The following is a description of a gene set: Genes up-regulated in CD34+ hematopoetic cells by expression of NUP98-HOXA9 fusion off a retroviral vector at 16 days after transduction. Human Gene Set: TAKEDA_TARGETS_OF_NUP98_HOXA9_FUSION_16D_UP NUP98-HOXA9, the chimeric protein resulting from the t(7;11)(p15;p15) chromosomal translocation, is a prototype of several NUP98 fusions that occur in myelodysplastic syndromes and acute myeloid leukemia. We examined its effect on differentiation, proliferation, and gene expression in primary human CD34+ hematopoietic cells. Colony-forming cell (CFC) assays in semisolid medium combined with morphologic examination and flow cytometric immunophenotyping revealed that NUP98-HOXA9 increased the numbers of erythroid precursors and impaired both myeloid and erythroid differentiation. In continuous liquid culture, cells transduced with NUP98-HOXA9 exhibited a biphasic growth curve with initial growth inhibition followed by enhanced long-term proliferation, suggesting an increase in the numbers of primitive self-renewing cells. This was confirmed by a dramatic increase in the numbers of long-term culture-initiating cells, the most primitive hematopoietic cells detectable in vitro. To understand the molecular mechanisms underlying the effects of NUP98-HOXA9 on hematopoietic cell proliferation and differentiation, oligonucleotide microarray analysis was done at several time points over 16 days, starting at 6 hours posttransduction. The early growth suppression was preceded by up-regulation of IFNbeta1 and accompanied by marked up-regulation of IFN-induced genes, peaking at 3 days posttransduction. In contrast, oncogenes such as homeobox transcription factors, FLT3, KIT, and WT1 peaked at 8 days or beyond, coinciding with increased proliferation. In addition, several putative tumor suppressors and genes associated with hematopoietic differentiation were repressed at later time points. These findings provide a comprehensive picture of the changes in proliferation, differentiation, and global gene expression that underlie the leukemic transformation of human hematopoietic cells by NUP98-HOXA9. species: Homo sapiens from publication Takeda A, Goolsby C, Yaseen NR (PMID 16818636), and this is the list of marker genes: FHL2, SMPDL3A, FN1, CDC42EP3, SMYD3, DUSP4, FCER2, IFIT1, HOXA3, HOXB-AS3, TOX, HBB, EPSTI1, GPX7, NEGR1, LUM, APCDD1, PTGS2, CD1D, PALLD, SIGLEC6, SLC5A3, IFI27, B3GALNT2, LIF, XYLT1, OAS2, BCL2L11, AHR, PRSS3, HBG1, S1PR3, ASB2, ABCD2, ATP10A, HBA1, CLECL1P, CD1C, MAP4K1 (mitogen-activated protein kinase kinase kinase kinase 1), GAPT, SLC12A8, MCOLN2, CD300LD-AS1, TSLP (NCBI Gene Id 85480), CMPK2, IRX3, SLAMF7, NDRG2, CFI, IFIT3, USP18, TNFSF10, SLC45A3, TESPA1, LILRA1, TPSAB1, APH1A, AP1S3, DEFB1, NRG1, CLEC4D (C-type lectin domain family 4 member D), AFF3, REN, PTPRK, LSP1, IFIT2, C12orf75, XAF1, ABCB1, ENSG00000304732, MEF2D, ASPHD2, CD1A, MEIS1, FLNB, CFP, GEM, LY6E, PCDH20, BEND6, GPR18, IFI6, CFD, DENND5B, HOXA7, CLNK, SLITRK4, LTBP1, HOMER2, EREG, LAMP3, IL6ST, CD38, IFI44, TMEM200A (transmembrane protein 200A), CPA3, RAB27B, ADRB1, PTGFR, CCR2, TOX-DT, PRKAR2B (protein kinase cAMP-dependent type II regulatory subunit beta), SAMHD1, AUTS2, MX1, GNAI1, THBS1, CCNA1, IFI44L, IRF4, ELOVL6, ADGRA2, OAS3, HOXB2, MPP7, HPGD, RAB33A, TDRD9, SLC18A2, IFITM1, CES1, BTLA, ITGB7, CHST2, IKZF1, RSAD2, LPAR3, C15orf48, CDH17, PDLIM1, SOX4, HOXB3, CCR6, DCANP1, WT1, OASL, PPP1R16B, ITGA7, PKIB, TRDC, IDO1, LGALS2, SLC38A1, ANKRD22, STAT1, TIFAB, SIGLEC17P, LAMP5, PRKAR1A, CD1E, HDAC9, IL31RA, OPN3 (opsin 3), NCALD, TFR2, NET1, FCAR, ZDHHC17, GPR82, SPINK2, KIT, TMT1B, TGM5, MX2, NAPSB, LBH, DCST1-AS1 (DCST1 antisense RNA 1), FGL2, ADAM19, ISG15, ATP11A, HOPX, HOXA9, ABCB4, HOXA5, HBD, FKBP1B, ZNF366 (zinc finger protein 366)